The following is a description of a gene set: Mouse Gene Set: MIR_6900_5P from publication Chen Y, Wang X (PMID 31504780) Genes predicted to be targets of miRBase v22 microRNA mmu_miR_6900_5p in miRDB v6.0 with MirTarget v4 prediction scores > 80 (high confidence targets). species: Mus musculus, and this is the list of marker genes: Rcan2, Rassf10, Exosc3, Smchd1, Krt14, Psd3, Crispld1, Serpinb9c, Zfp521, Arhgap1, Kbtbd8, Mprip, Prkcg, Ppp1r11, Ppp2r5a, Pnkd, Cdipt, Dnmt3b, Plxdc1, Eef2k, Atp23, Rbm14, Slc25a32, Zcchc17, Jag1, Pacs1, Hdgfl1, Lrrc39, Ankrd6, Ugt2a1, Rcor2, Mmp24, Ubn2, Cox8a, Ssh2, Iqce, Cdk5r1, Trp53inp2, Gna13, Aak1, Tmem131, Kcnab3, Adgre4, Tet3, Dhdds, Trpc5, Man2a2, Scamp5, Rnf166, Th, Inpp5e, Tbrg1 (NCBI Gene Id 21376), Tfe3, Naa60, Pcdh12, Arhgap44, Krtap17-1, Dars2, Arfip2, Tnks, Chad, Ednra, Rp1, Otop1, Eps8l1, Tom1l2 (target of myb1-like 2 (chicken)), Olfm3, Sp1, Lmo2, Gria2, Dusp16, Ereg, Tm9sf3, Ksr2, Txnl4a, Mtcl2, Rack1, Brd3 (NCBI Gene Id 99302), Col4a4, Crim1, Opn4, Umodl1, Zmpste24, Ulk1, Evi5, Mark2, Cav1, Natd1, Serpina3m, Pate5, Ugt2a2, Ldah, H60c, Hoxb1, Rubcn, Ndufs1, Ldb2, Ifit3b, Ifit3, Tcte1, Kif1b, Scai, Sap30bp, Ptk7, Gm5916, Itpkb, Tvp23a, Tmx4, Rapgefl1, Phex, Vezf1, Dnaja4, Zfp65, Tsc22d2, Osbp2, Ptgdr2, Pdk1, Tmem33, Agap2, Oosp2, Fos, Nme7, Dhcr24, 9030624G23Rik, Sprr2d, Ubash3a, Dcun1d1, Elk1 (ELK1, member of ETS oncogene family), Rmnd5b, Oscp1, Mtmr4, Nr4a3, Abl2, 4921536K21Rik